The following is a description of a gene set: Generalized abnormal accumulation of fluid beneath the skin, or in one or more cavities of the body. studied in species Homo sapiens Generalized edema Human Gene Set: HP_GENERALIZED_EDEMA, and this is the list of marker genes: CD55, CFH, PMM2, CALCRL, TMEM260, POLG, PHGDH, NPHS1, DEF6, UBR1, MYLK, PRKAG2, PRF1, PLVAP, MOGS, HELLPAR, ARHGDIA, DPAGT1, FARSB, CD46, NOS1AP (nitric oxide synthase 1 adaptor protein), PIEZO1, SCARB2, CFI, DOK7, IFT56, FSHR